Given this list of marker genes Thnsl2 (NCBI Gene Id 232078), Mthfd1, Plod3, Aass, Apip, Aasdhppt, Mri1, Mtrr, Bhmt, Bhmt1b (betaine--homocysteine S-methyltransferase 1B), Asnsd1, Mtap, Plod2, Bhmt2, Mthfr, Adi1, Got2, Mtr, Got1l1, Got1, Mthfd2l, Asns, Enoph1, here is a description of the gene set: The chemical reactions and pathways resulting in the formation of amino acids of the aspartate family, comprising asparagine, aspartate, lysine, methionine and threonine. Mouse Gene Set: GOBP_ASPARTATE_FAMILY_AMINO_ACID_BIOSYNTHETIC_PROCESS studied in species Mus musculus